The following is a description of a gene set: Genes important for implantation and uterine, based on mouse models with female fertility defects. Reproduction is required for the survival of all mammalian species, and thousands of essential 'sex' genes are conserved through evolution. Basic research helps to define these genes and the mechanisms responsible for the development, function and regulation of the male and female reproductive systems. However, many infertile couples continue to be labeled with the diagnosis of idiopathic infertility or given descriptive diagnoses that do not provide a cause for their defect. For other individuals with a known etiology, effective cures are lacking, although their infertility is often bypassed with assisted reproductive technologies (ART), some accompanied by safety or ethical concerns. Certainly, progress in the field of reproduction has been realized in the twenty-first century with advances in the understanding of the regulation of fertility, with the production of over 400 mutant mouse models with a reproductive phenotype and with the promise of regenerative gonadal stem cells. Indeed, the past six years have witnessed a virtual explosion in the identification of gene mutations or polymorphisms that cause or are linked to human infertility. Translation of these findings to the clinic remains slow, however, as do new methods to diagnose and treat infertile couples. Additionally, new approaches to contraception remain elusive. Nevertheless, the basic and clinical advances in the understanding of the molecular controls of reproduction are impressive and will ultimately improve patient care. Human Gene Set: MATZUK_IMPLANTATION_AND_UTERINE studied in species Homo sapiens from publication Matzuk MM, Lamb DJ (PMID 18989307), and this is the list of marker genes: LIFR, CSF1, PTGS2, HOXA11, FKBP4, IL11RA, WNT7A, NDP, HOXA10, HMX3, PAX8, HNF1A, LHX1 (NCBI Gene Id 3975), PGR, NCOA1, ACSL4, OVOL1, CENPB, TERT, CBS, DLGAP5, LPAR3